The following is a description of a gene set: Neurologically relevant genes modulated in brain tissue by a trans-regulatory QTL (quantitative trait locus) near D6Mit150 marker. from publication Chesler EJ, Lu L, Shou S, Qu Y, Gu J, Wang J, Hsu HC, Mountz JD, Baldwin NE, Langston MA, Threadgill DW, Manly KF, Williams RW (PMID 15711545) Patterns of gene expression in the central nervous system are highly variable and heritable. This genetic variation among normal individuals leads to considerable structural, functional and behavioral differences. We devised a general approach to dissect genetic networks systematically across biological scale, from base pairs to behavior, using a reference population of recombinant inbred strains. We profiled gene expression using Affymetrix oligonucleotide arrays in the BXD recombinant inbred strains, for which we have extensive SNP and haplotype data. We integrated a complementary database comprising 25 years of legacy phenotypic data on these strains. Covariance among gene expression and pharmacological and behavioral traits is often highly significant, corroborates known functional relations and is often generated by common quantitative trait loci. We found that a small number of major-effect quantitative trait loci jointly modulated large sets of transcripts and classical neural phenotypes in patterns specific to each tissue. We developed new analytic and graph theoretical approaches to study shared genetic modulation of networks of traits using gene sets involved in neural synapse function as an example. We built these tools into an open web resource called WebQTL that can be used to test a broad array of hypotheses. Mouse Gene Set: CHESLER_BRAIN_D6MIT150_QTL_TRANS studied in species Mus musculus, and this is the list of marker genes: Reln, Calm4, Mapk1, Gad1, Adra2b (adrenergic receptor, alpha 2b), Mapk6, Htr4, Slc6a1, Chrng